Given this list of marker genes ERCC4, RPA3, POLE4, XPA, POLK, LIG3, POLD3, POLE2, RPA1, POLD2, XRCC1 (X-ray repair cross complementing 1), GTF2H5, POLE3, GTF2H1, POLD4, LIG1, GTF2H3 (general transcription factor IIH subunit 3), ERCC2, GTF2H4, RPA2 (NCBI Gene Id 6118), POLD1, ERCC5, POLE, RPA4, PCNA, POLH, ERCC1, GTF2H2, ERCC3, here is a description of the gene set: studied in species Homo sapiens Pathway Definition from KEGG: (ERCC3+ERCC2+GTF2H) == ERCC5 == XPA == RPA -> (ERCC1+ERCC4) == XPA == RPA == ERCC5 -> PCNA == POLD,POLE,POLK,POLH -> LIG1,(LIG3+XRCC1) Human Gene Set: KEGG_MEDICUS_REFERENCE_CORE_NER_REACTION Core NER reaction. Pathway ID: N01431. Pathway type: Reference. Pathway class: nt06502 Nucleotide excision repair.